The following is a description of a gene set: from publication Shin DM, Shaffer DJ, Wang H, Roopenian DC, Morse HC 3rd (PMID 19010892) Mouse Gene Set: SHIN_B_CELL_LYMPHOMA_CLUSTER_1 Cluster 1 of genes distinguishing among different B lymphocyte neoplasms. studied in species Mus musculus Aside from Myc-activating translocations characteristic of plasmacytomas (PCT), little is known about genetic factors and signaling pathways responsible for the development of spontaneous B-cell lineage lymphomas of mice. Here, we characterized the transcriptional profiles of PCT, centroblastic diffuse large B-cell lymphomas (CBL), and high-grade splenic marginal zone B-cell lymphoma (MZL++) using high-throughput quantitative reverse transcription-PCR. Expression profiles of CBL and MZL++ were strikingly similar and quite unlike that of PCT. Among the genes expressed at significantly higher levels by PCT were a number involved in NOTCH signaling, a finding supported by gene set enrichment analyses of microarray data. To investigate the importance of this pathway, NOTCH signaling was blocked in PCT cell lines by treatment with a gamma-secretase inhibitor (GSI) or transduction of a dominant-negative mutant of MAML1. These treatments resulted in reduced expression of NOTCH transcriptional targets in association with impaired proliferation and increased apoptosis. GSI treatment of transformed plasma cells in a primary PCT also induced apoptosis. These results integrate NOTCH activation with oncogenic signaling pathways downstream of translocated Myc in the pathogenesis of mouse PCT, two signaling pathways also implicated in development of human multiple myeloma and T-cell lymphoblastic lymphoma., and this is the list of marker genes: Ccl3, Hoxd11, Hells, Irf1, Nos2, Tcl1, Mnx1, Dvl2, Cxcl9, Il10, Ifng, Ptch2, Rad52